Given this list of marker genes CCDC141, CDC40, EEF2KMT (NCBI Gene Id 196483), ACACB, MFSD6, DMRTC1B, HAUS2, GMCL1, PDE11A, SH3PXD2A, WDHD1, ARPC1A, CCDC24, SPTBN4, TMEM170B, GRIA3, ISG20, SH3TC2, GLG1, MPZL3, PRXL2C (NCBI Gene Id 203335), TNRC6C, EPHB1, ODF2L, PIAS2, HNRNPUL2, ZNF26, MAP2K4, CD163, RTP1, ENOSF1, KATNBL1, ADRB1, ARL17A, EMX2, EPO, FAM86C1P, SRSF1, PAX1, DBNDD2, TRIM8, DMRTC1, TNPO3, ZNF14, HIPK3, CLMN, PTPN7, GCNA, BACE1, GANC, SLC24A2, CNOT4, ELAVL4, TBC1D7, RPL32, VWA8, MLPH (NCBI Gene Id 79599), CD300E, SRFBP1, CAPRIN1, MYZAP, GNL3L, ACKR2, FAM86B1, C8orf76, SEC23IP, FGF13, GALNT13, DTD2, NRXN3, KCNB1, CLN8, here is a description of the gene set: Genes predicted to be targets of miRBase v22 microRNA hsa-miR-5699-3p in miRDB v6.0 with MirTarget v4 prediction scores > 80 (high confidence targets). species: Homo sapiens Human Gene Set: MIR5699_3P from publication Chen Y, Wang X (PMID 31504780)